The following is a description of a gene set: studied in species Mus musculus Mouse Gene Set: GOBP_TRACHEA_FORMATION The process pertaining to the initial formation of a trachea from unspecified parts. The process begins with the specific processes that contribute to the appearance of the discrete structure and ends when the trachea is recognizable. The trachea is the portion of the airway that attaches to the bronchi as it branches., and this is the list of marker genes: Mapk3, Map2k2, Mapk1, Ctnnb1, Bmp4, Map2k1, Tgfbr2